The following is a description of a gene set: Mouse Gene Set: REACTOME_RESOLUTION_OF_SISTER_CHROMATID_COHESION Resolution of Sister Chromatid Cohesion studied in species Mus musculus, and this is the list of marker genes: Bub1b, Spdl1, Sgo1, Cdc20, Ranbp2, Ckap5, Dync1h1, Nudc, Tubb4b, Spc24, Clasp1, Tuba8, Tubb4a (tubulin, beta 4A class IVA), Firrm, Cdca8, Dynll1, Cenps, Ppp2r5b, Ccnb1, Mis12, Spc25, Stag1 (NCBI Gene Id 20842), Aurkb, Tuba1a, Kntc1, Ppp2r5e, Tuba3b, Nsl1, Cenpu, B9d2, Stag2 (STAG2 cohesin complex component), Cenpe, Ppp2cb, Dsn1, Tubb2a, Dync1i1, Ndc80, Incenp, Ppp2r5d, Cenpf, Mapre1, Ppp2r1b, Nup107, Dync1li1, Plk1, Ppp2r1a, Cenpq, Nup160, Ska1, Nup43, Taok1, Ppp2ca, Bub1, Smc1a, Cenpc1, Mad1l1, Tubb6, Cenpo, Nuf2, Cenpa, Kif18a, Pds5b, Tubb3, Cdca5, Rcc2, Rps27, Rad21, Tuba1b, Cenpi, Nup98 (NCBI Gene Id 330609), Kif2a, Ccnb2, Cenpm, Kif2c, Pafah1b1, Ndel1, Cenpl, Clasp2, Cenpk, Cenpt, Cdk1, Ppp1cc (NCBI Gene Id 627816), Cenpn, Cenph, Clip1, Ppp2r5a, Pmf1, Tubb2b, Nup37, Dync1i2, Seh1l (SEH1-like (S. cerevisiae), Itgb3bp, Bub3, Ahctf1, Nde1, Zwilch, Hdac8, Tubal3, Zw10 (zw10 kinetochore protein), Sgo2a, Tubb1, Wapl, Smc3, Pds5a, Zwint, Dynll2, Sec13, Rangap1, Nup85, Dync1li2, Ercc6l, Tuba1c, Tuba4a, Tuba3a, Ppp2r5c, Rps27rt, Nup133, Kif2b, Cenpp, Ska2, Xpo1, Mad2l1 (MAD2 mitotic arrest deficient-like 1)